The following is a description of a gene set: Any process that modulates the occurrence or rate of activation-induced cell death of T cells. studied in species Mus musculus Mouse Gene Set: GOBP_REGULATION_OF_ACTIVATION_INDUCED_CELL_DEATH_OF_T_CELLS, and this is the list of marker genes: Ripk3, Fadd, Tsc22d3 (NCBI Gene Id 14605), Cd47, Tgfb2, Gpam, Tnfsf4, Tnfrsf4